Given this list of marker genes SCD5 (NCBI Gene Id 79966), ACSL3, PPT1, HACD3, ELOVL6, HACD4, PPT2, ELOVL3, TECRL, HSD17B12, TECR, SLC27A3, CBR4, HACD2, ACSL5, FASN, ACACA, ELOVL7, ACLY, ACSBG1, ACSL1, ELOVL5, HSD17B3, OLAH, ACSBG2, HSD17B8, ELOVL1, ACSL4, HTD2, MORC2, ELOVL2, ACSL6, SLC27A2, HACD1, SCD, ELOVL4, ACSF3, here is a description of the gene set: Human Gene Set: REACTOME_FATTY_ACYL_COA_BIOSYNTHESIS species: Homo sapiens Fatty acyl-CoA biosynthesis